The following is a description of a gene set: The directed movement of inorganic anions into, out of or within a cell, or between cells, by means of some agent such as a transporter or pore. Inorganic anions are atoms or small molecules with a negative charge which do not contain carbon in covalent linkage. species: Homo sapiens Human Gene Set: GOBP_INORGANIC_ANION_TRANSPORT, and this is the list of marker genes: SLC25A14, KCNQ1 (NCBI Gene Id 3784), ATP8B1, SLC6A14, SLC4A8, ATF4, SLC17A8, GABRP, SLC17A1, CA7, GABRB3, SLC4A3, GLRA3, KCNK1, GLRB, SLC5A8, GABRQ, CLIC1, BEST4, SLC26A6, SLC1A1, SLC22A11, SLC26A4, CLIC6, TG, GABRB1, SLC4A11, FGFR1, SLC12A8, SLC12A1, BEST1, CLCN1, SLC26A5, CLDN4, SLC26A8, CLCN3, SLC26A9, BSND, SLC34A3, SLC4A1, TTYH1, CLCA4, SLC17A3, SLC25A10, GABRR2, GABRG1, ANO8, FGF23, MFSD5, SLC12A7, SLC22A8, SLC4A5, BEST2, ANO4, RACGAP1, CLCN4 (chloride voltage-gated channel 4), P2RY4, VDR, SLC6A1, CLCNKB, ANO2, SLC34A1, WNK4, GABRA5, SLC26A11, SLC5A5, SLC37A1, SLC5A1, OSTM1, GABRA6, GABRR3, ANO3, SLC25A27, P2RX5 (NCBI Gene Id 5026), CLIC4, CLCA1, NMUR2, SLC12A5, SLC25A3, ABCC6, SLC12A2, SLC20A2, NMUR1, CLDN3, SFRP4, SLC1A7, GLRA2 (NCBI Gene Id 2742), SLC5A6 (solute carrier family 5 member 6), SLC37A4, BEST3, SLC17A4, P2RY6, CLCN5, CLIC3, XPR1, TTYH2, FXYD3, GABRD, CFTR, OCA2, SLC1A4 (solute carrier family 1 member 4), SLC1A3, SLC12A9, SLC13A1, APOL1, SLC26A2, LRRC8A, ANO1, PACC1, GABRA3, KCNK2, SLC12A3, ADAMTS8, SLC25A30, SLC6A2, SLC11A1, CLIC2 (NCBI Gene Id 1193), MFSD8, CLCA2, ANKH, SLC37A2 (solute carrier family 37 member 2), CLCN6, SLC26A1, GABRA2, SLC22A6, DCD, SLC17A6, GABRG2, CLDN17, SLC4A9, SLC12A6, SLC4A4, SLC17A2, SLC26A3, ANO10, GABRR1, CRY2, ANO9, GABRA1 (NCBI Gene Id 2554), SLC34A2, TTYH3, ANO5, CLCNKA, CLCN7, CLCN2, ABCB1, CLIC5, CEBPB, TSPO, ENPP3 (NCBI Gene Id 5169), GLRA1, CASR, SLC12A4 (solute carrier family 12 member 4), CA2, SLC20A1, GABRG3, SLC4A2, SLC17A7, SLC13A4, ENPP1, PRKG2, GABRA4, SLC26A7, SLC37A3, ANO6, SLC4A10, UCP2, CLCC1, GABRB2, TMC4, AQP6, CLNS1A, FXYD1, SLC26A10P, SLC4A7, GABRE, ANO7 (anoctamin 7)